Given this list of marker genes LPAR3, SCN4B, SLC38A4, ADGRL3, CRADD, STAT1, ZNF438, ZKSCAN8P1, AHRR, OTC, SLITRK6, PLAT (NCBI Gene Id 5327), TERF2, CSE1L, LAG3, DAPL1, TDRD1, CCSER1, XYLT2, FIGLA, CYBA, LRRN1, ACTN1, LRTM2, SERPINA10, DGAT2, TMEM59L, SLC26A6, DNAJC22, B3GALT1, MPP3, SPACA1, RNF113A (NCBI Gene Id 7737), OASL (2'-5'-oligoadenylate synthetase like), PCYOX1L, KRT84, AKIRIN1 (akirin 1), ADHFE1, POLR2I, EPHB1, SARAF, RALGPS2, MRPS9, ALDH1B1, HS3ST3A1, KMO, SRPK3, TEC (tec protein tyrosine kinase), TMEM41B (NCBI Gene Id 440026), UQCC2, IER3IP1, FOXN2, SLC13A5, GAD2, SMIM19, AGXT2, NUDT15, LSM14B, MAGEA11, HECW2, SSBP4, CIAPIN1, BTBD19, TGFBR3, KRT75, ACACA, TRIB2, TXNDC2, IGFBP4, ADM, TMEM204 (transmembrane protein 204), MAOA, KRT33A, HECW1, XKR4, TM2D1, F2R, DEXI, SELENOP, MRPL58, PLA2G12B, SPSB1, CDH13, TOE1 (NCBI Gene Id 80147), MDH2, FANCF, FETUB, APOBEC2, COX14 (cytochrome c oxidase assembly factor COX14), SCG5, GSTT1, DAW1, ZNF142, IL36RN, IPO11, ETV4, ZFP2, GRHPR, ARHGAP23, KREMEN1, NFU1, MCTP2, ITK, RCN3, ITM2A, PNPLA1, CEP20, POSTN, CA7, DCLRE1B, RIT2, SLC16A5, NRXN1, CR2, MRPL23, ADGRL4, SLC26A7, CPQ, LDHA, LARS2, MRPL12 (NCBI Gene Id 6182), TSPAN11, CKB, GUCD1, LRRC75B, LDB2, XKRX, AGR2, ZMYND19 (NCBI Gene Id 116225), TSPAN9 (tetraspanin 9), FKBP3, FAM20A, ICA1L, GREM1, DZIP1, YOD1, XKR5, FAM83H, ADH1C, UQCC5, LAT, ABCC2, MROH2B, COQ6, NSUN6, ASCL2, A1CF, UCMA, THOC1, TMEM212, TIMP1, RPL19, NANS, IL1RAPL2, DACH2, LHFPL3, TOR1A, MINAR2, HERC3, THEMIS, CUEDC1, HACD2, DTWD2, R3HDM1, IYD, BCL2L10, NECAB3, SET, GTF3C2, ZFP90, NPFF, ECSIT, TBRG4, LYZL4, SETD4, BHLHE22, UCK1, PRX, GHSR, LGALS7, ITGB5, CIMIP5, FABP2, PNPLA5, GPR25, DIMT1, LOXL2, ECD, PCDHB2, RNFT1, C1orf52, TMEM163, RRAGC, KDM4D, NDUFB10, CCL25, SGK3, PDK1, EYA2, here is a description of the gene set: To investigate the early host response triggered by three different strains of Trypanosoma cruzi at a local infection site, changes in host gene expression were monitored in a murine intradermal infection model using Affymetrix oligonucleotide arrays. Robust induction of IFN-stimulated genes (ISGs) was observed in excised skin 24 hours post-infection where the level of ISG induction was parasite strain-dependent with the least virulent strain triggering a muted IFN response. Infection of mice immunodepleted of IFNγ-producing cells or infection of IFNγ-deficient mice had minimal impact on the IFN response generated in T. cruzi infected mice. In contrast, infection of mice lacking the type I IFN receptor demonstrated that type I IFNs are largely responsible for the IFN response generated at the site of infection. These data highlight type I IFNs as important components of the innate immune response to T. cruzi the site of inoculation and their role in shaping the early transcriptional response to this pathogen. We used microarrays to detail the local host transcriptional response to intradermal T. cruzi infection in WT mice and mice depleted of NK cells, or deficient in IFN-gamma or type I IFN responses. Additionally we compared the local host-transcriptional response generated to infection with 3 different strains of Trypanosoma cruzi (Y, Brazil, and G). Human Gene Set: GSE13522_WT_VS_IFNAR_KO_SKING_T_CRUZI_Y_STRAIN_INF_DN studied in species Homo sapiens from publication Chessler AD, Unnikrishnan M, Bei AK, Daily JP, Burleigh BA (PMID 19201883) Genes down-regulated in skin after injection of Trypanosoma cruzi (strain Y): wildtype (BALB/c) versus IFNAR1 knockout.